The following is a description of a gene set: Binding to a retromer complex. Human Gene Set: GOMF_RETROMER_COMPLEX_BINDING species: Homo sapiens, and this is the list of marker genes: WASHC2C, SNX3, IGF2R, M6PR, SLC11A2, TBC1D5, WASHC2A, RCSD1, SORT1, RAB7A